The following is a description of a gene set: Mouse Gene Set: GOBP_ESTABLISHMENT_OR_MAINTENANCE_OF_BIPOLAR_CELL_POLARITY species: Mus musculus Any cellular process that results in the specification, formation or maintenance of a bipolar intracellular organization or cell growth patterns., and this is the list of marker genes: Ift20, Pdcd6ip, Lrrc7, Spag6l (NCBI Gene Id 50525), Fat1, Wnt11, Cdx2, Dlg5, Lhx2, Prickle2, Ezr, Pard3 (par-3 family cell polarity regulator), Msn, Rhoa, Mtcl1, Pard6a, Crb1, Dlg1, Cdc42, Tcf15, Llgl1, Myo9a, Lama1, Wnt5a, Dlg3, Pard3b (par-3 family cell polarity regulator beta), Ptk7, Ilk, Ooep, Syne4, Fscn1, Pals1, Foxf1, Scrib, Vangl2, Crb2, Sh3bp1, Wdr1, Mark2 (NCBI Gene Id 13728), Patj, Dlg2, Camsap3, Crb3, Nherf1, Arf4, Ophn1, Prkci, Ttc8 (tetratricopeptide repeat domain 8), Foxj1